Given this list of marker genes TRIT1 (NCBI Gene Id 54802), EPAS1, HLA-DQA1, IMMP1L, ENTPD4, UPB1, RPL36A, SPIB, ACTN1, ACADL, HSD11B1, WDR76, NGDN, EPHX4, RUNDC3B, NPC2, NAP1L4, CKLF, KNOP1, ANAPC13, SNHG8, NDUFA10, SLC28A2, EPB41L1, TMEM216, TGFBR2, CRTAM, ZNF652, HS3ST3B1, KDM5D, ACVRL1, WDFY4, CHDH, SLC6A19, PACC1, MKKS, ADH1C, SLPI, OSTF1, RSU1, VTI1B, UNC5A, SEMA4F, DSE (dermatan sulfate epimerase), MCTP2, GRAMD2B, DNTT, RRAGA, PXYLP1 (NCBI Gene Id 92370), SBDS, FGF13, ITGAX, ZNF180, AFP, ACAT1, TENT5A, ATP5MG, RAB3GAP1, BBS9, GMFG, TENT5C, PTGR3, PVT1, TMEM107, TMIE, TYROBP, APP, IFT25, SNRPG, ST8SIA1, RFLNB, SIKE1, FH, LBP, PITPNA, DDB2, CYBB, SLC16A5, ADAT2 (NCBI Gene Id 134637), GPSM2 (NCBI Gene Id 29899), KIF23, PDLIM4, SLC9A9, FOCAD, FAM78B, BTG2, KIFBP, XKRX, HLA-DRB1, RANBP10, HLA-DOB, COA6, NYNRIN, ATP1B1 (ATPase Na+/K+ transporting subunit beta 1), SSRP1, PADI2, AP1M2, RAD23B, WDR41, PPP1R1A, SUGT1, CCND1, MRPS5 (NCBI Gene Id 64969), RAB2A, ARHGAP29, HES2, ICOSLG, IL17B, IGLC7, LYPD6B, ALG8, MID1IP1, KLRD1, SGK1, INSL6, ATP8B4, ITK, SUPT7L, ZWINT, COX16, PPM1J, TXNDC15, SARAF, ANKH, ACTN2, MRPL33, H2BC13, VOPP1, CCL5, MYLIP, IFI30, TMEM243, APPL2, IER3IP1, OAT, CTPS1, RASD2, SNRPD3, MPEG1, ACER2, MED17, TBC1D5, BPNT1, QPCT, LRRC1, RNF122, ARL4C, RGMB, PPRC1, NAAA, ARSB, KLHL12, ANXA1, RAD51C, RPS19, RAB27A, LAPTM4A, ALOX5AP, TSPAN14, SEC11A, BMP7, EMB, HDDC2, SMAD1 (NCBI Gene Id 4086), SETD6, SLC20A1, DTD1, FCER1G, PRF1, PDE2A, SGMS1, RGCC, GPATCH4, SESTD1, CHCHD3, SCP2, AGK, DAPL1, LY6D (NCBI Gene Id 8581), POLE4, CPM, NTRK3, P4HA1 (prolyl 4-hydroxylase subunit alpha 1), APOBR, ZNF205, ASRGL1, PDIA6, NACC2, TANC1, CREG1, TGFBR3, DROSHA, FASLG, METTL1, AMIGO2, DDX3Y, ATP6V1D, PDK1, PLD4, SRPX, here is a description of the gene set: Human Gene Set: GSE13522_WT_VS_IFNAR_KO_SKIN_UP To investigate the early host response triggered by three different strains of Trypanosoma cruzi at a local infection site, changes in host gene expression were monitored in a murine intradermal infection model using Affymetrix oligonucleotide arrays. Robust induction of IFN-stimulated genes (ISGs) was observed in excised skin 24 hours post-infection where the level of ISG induction was parasite strain-dependent with the least virulent strain triggering a muted IFN response. Infection of mice immunodepleted of IFNγ-producing cells or infection of IFNγ-deficient mice had minimal impact on the IFN response generated in T. cruzi infected mice. In contrast, infection of mice lacking the type I IFN receptor demonstrated that type I IFNs are largely responsible for the IFN response generated at the site of infection. These data highlight type I IFNs as important components of the innate immune response to T. cruzi the site of inoculation and their role in shaping the early transcriptional response to this pathogen. We used microarrays to detail the local host transcriptional response to intradermal T. cruzi infection in WT mice and mice depleted of NK cells, or deficient in IFN-gamma or type I IFN responses. Additionally we compared the local host-transcriptional response generated to infection with 3 different strains of Trypanosoma cruzi (Y, Brazil, and G). studied in species Homo sapiens Genes up-regulated in skin: wildtype (BALB/c) versus IFNAR1 knockout. from publication Chessler AD, Unnikrishnan M, Bei AK, Daily JP, Burleigh BA (PMID 19201883)